The following is a description of a gene set: Human Gene Set: TSUDA_ALVEOLAR_SOFT_PART_SARCOMA from publication Tsuda M, Davis IJ, Argani P, Shukla N, McGill GG, Nagai M, Saito T, Laé M, Fisher DE, Ladanyi M (PMID 17283122) Specific chromosomal translocations encoding chimeric transcription factors are considered to play crucial oncogenic roles in a variety of human cancers but the fusion proteins themselves seldom represent suitable therapeutic targets. Oncogenic TFE3 fusion proteins define a subset of pediatric renal adenocarcinomas and one fusion (ASPL-TFE3) is also characteristic of alveolar soft part sarcoma (ASPS). By expression profiling, we identified the MET receptor tyrosine kinase gene as significantly overexpressed in ASPS relative to four other types of primitive sarcomas. We therefore examined MET as a direct transcriptional target of ASPL-TFE3. ASPL-TFE3 binds to the MET promoter and strongly activates it. Likewise, PSF-TFE3 and NONO-TFE3 also bind this promoter. Induction of MET by ASPL-TFE3 results in strong MET autophosphorylation and activation of downstream signaling in the presence of hepatocyte growth factor (HGF). In cancer cell lines containing endogenous TFE3 fusion proteins, inhibiting MET by RNA interference or by the inhibitor PHA665752 abolishes HGF-dependent MET activation, causing decreased cell growth and loss of HGF-dependent phenotypes. MET is thus a potential therapeutic target in these cancers. Aberrant transcriptional up-regulation of MET by oncogenic TFE3 fusion proteins represents another mechanism by which certain cancers become dependent on MET signaling. The identification of kinase signaling pathways transcriptionally up-regulated by oncogenic fusion proteins may reveal more accessible therapeutic targets in this class of human cancers. studied in species Homo sapiens Protein kinase genes most significantly up-regulated in ASPS (alveolar soft part sarcoma) tumors compared to four other types of primitive sarcomas., and this is the list of marker genes: MKNK2, MAPKAPK2, PIM1, MAPK3, HSPB8, PCK2, PACSIN2, PRKAG2, LYN, MET